The following is a description of a gene set: Genes predicted to be targets of miRBase v22 microRNA hsa-miR-4642 in miRDB v6.0 with MirTarget v4 prediction scores > 80 (high confidence targets). Human Gene Set: MIR4642 from publication Chen Y, Wang X (PMID 31504780) studied in species Homo sapiens, and this is the list of marker genes: CD164, KLHL2, TBC1D8, ALKBH8, PI4K2B, FNDC3B, LARS2, SHISA7, DUSP10, STOX2, TSHR, SH3BP5, ARMC10, KSR2, RAB2A, RICTOR, PCSK5, SLC25A42, SMIM13, TMED2, APELA, ANKRD10, PPP3CA, MAP3K9, ZNF697, SOBP, CORO2B, TARBP1, KCNK2, SLAIN2, FAM199X, RBM18, PRKAR2B, STAR, XPO1, DAAM1, RBM15, LIN28A, MYO1C, TTC39A, RALGPS1, PHAF1 (NCBI Gene Id 80262), ADORA3, SCAF8, RUVBL1, NUDT13, NPNT, TIAM1, UBN2, REPS2, MACIR, BCAT2, GLRB, PKNOX2, CMTR1, SELENOI (selenoprotein I), SLC25A16, AIFM2, SKIL, TMEM132C, PPP3CB, ABRAXAS2, MKX, WASF2, PBX2, ATXN3, MRPS18C, RBFOX1, RAP2B, TTC28, RPS6KA5, AUH, PER2, SESN3, PGRMC2, PDE7A, PHYHIPL, TSC1, HAS2, CBX2, RUFY2, ETF1, CCN4, SGMS1, SLC35G1, ZIC3, PRTG, SPRY3, UBE2K, CADM1, FRMPD4, HES1, CABLES2, LMOD1, POLG, ZCCHC4, AAMDC, KICS2, ZBTB20, COX7B, CLIC5, FLT1